Given this list of marker genes SSH1, FRRS1L, SHISA6 (NCBI Gene Id 388336), ZDHHC2, SHISA7, SLC7A11, here is a description of the gene set: species: Homo sapiens Human Gene Set: GOBP_REGULATION_OF_GLUTAMATE_RECEPTOR_CLUSTERING Any process that modulates the frequency, rate or extent of glutamate receptor clustering.